The following is a description of a gene set: from publication Cipolletta D, Feuerer M, Li A, Kamei N, Lee J, Shoelson SE, Benoist C, Mathis D (PMID 22722857) We identified Pparg as a major orchestrator of the phenotype of adipose-tissue resident regulatory T cells (VAT Tregs). To explore the contribution of Pparg1 and 2 in the generation of the VAT Tregs-specific gene signatures, CD4+FoxP3- T cells were transduced with Foxp3+/- Pparg1 (or Pparg2), treated with Pioglitazone or vehicle, and double sorted for microarray analysis. Human Gene Set: GSE37533_PPARG1_FOXP3_VS_PPARG2_FOXP3_TRANSDUCED_CD4_TCELL_UP Genes up-regulated in CD4 T cells over-expressing: FOXP3 and PPARg1 isoform of PPARG versus FOXP3 and PPARg2 isoform of PPARG. studied in species Homo sapiens, and this is the list of marker genes: XPNPEP3, TNK2, ZC3H7B, RABAC1, FEM1A, BHLHE40, KAT2A, NAA16, RALGAPA2, MSN, PKP4, GPATCH11, ZBTB2, ST13, LIPF, CDC123, ATR, RNF103, MLYCD, RPF2, AAGAB, WRAP73, BCS1L, CRNKL1, RYK, SRP19, GPR65, GCSH, SLC16A10, B9D2, SLC30A6, FAM53B, RPS6KA1, TMEM18, ATOSA (NCBI Gene Id 56204), WDR18, FOXJ2, C6orf89, SSBP2, NR4A1, POLR3F, AKAP8L, PHF2, C7orf25, DIDO1, GOLGA4, TBCEL, OPA3, TMEM192, FOXP1, UNKL, ATXN7L3, MEN1, THUMPD2, MINDY3, EDC4, BSG, SPEN, NOL6, RPP21, COQ9, YIPF3, SMOX, LYPLA2, PRRC2C, TMEM41A, SRPK1, CTU2, KCTD12 (NCBI Gene Id 80710), OTULIN, ATF4, PTMA, TK2, SNRPD1, PPIA, SAMD8, PRKRIP1, SIPA1, AXIN1, MICALL1, CELF2, PROZ, ARHGAP9, RNF11, PPP1R16A, TBP, NUDT7, TRAIP, MAML1, METTL15, ZCCHC17, TXN2, DOCK8 (NCBI Gene Id 81704), MED4, PAICS (phosphoribosylaminoimidazole carboxylase and phosphoribosylaminoimidazolesuccinocarboxamide synthase), ATP11B, GTF2IRD2, SAC3D1, FAM118B, MBNL2, DPM3, KRBA1, POU5F2, SMIM11, APOBEC1, AP1M2, PCGF2, CPNE7, MRPL52, AOC2, PRCC, ELP4, RREB1, GNG2 (NCBI Gene Id 54331), RDH10, CDH17, IPMK, FAM76B, THUMPD3, NBEAL2, DICER1, LAMB3, TMEM11, CDC42SE2, BID, ZDHHC3, BOD1L1, MARCHF8, ARHGEF7, TRAPPC12, RAD17, SLC37A1, SLC15A3, VPS50, FRYL, DFFA, RAPGEF1, PTPN13 (protein tyrosine phosphatase non-receptor type 13), UBXN11, DCLRE1C, CXXC1, BCL7A, DAD1, PLEKHF1, SF1, RHOC, ANKRD54, PRPF40A, DGKZ, AGO2, TNP2, INSYN2B, ESS2, RPS6KB1, DDX27, SDHB, CMAS, DCLRE1B (NCBI Gene Id 64858), TMEM199, PRRC2B, TNFSF10, AMPD2, NSRP1, GATAD2A, COMMD9, SP2, ZMAT3, IKZF5, PPM1H, DUSP19, RPE65, PIGX, FHIP2B, PEX3, DDX46, USP10, SLC39A9, ZBTB8A